The following is a description of a gene set: Mouse Gene Set: GOCC_ACETYLTRANSFERASE_COMPLEX studied in species Mus musculus A protein complex which is capable of acetyltransferase activity., and this is the list of marker genes: Morf4l1, Map3k7, Kat2a, Ogt, Kat2b, Taf6, Epc2, Epc1, Ep400, Tada1, Naa35, Dld, Actbl2, Hcfc1, Yeats2, Morf4l2 (NCBI Gene Id 71961), Naa11, Taf7, Brpf1, Naa30, Dlat, Pdha2 (pyruvate dehydrogenase E1 alpha 2), Naa38, Actg1, Sgf29, Ruvbl1, Kat6b, Taf12, Kansl1, Naa15, Crebbp (NCBI Gene Id 547230), Phf20, Naa20, Brpf3, Tada2a, Ing5, Sf3b3, Eny2, Brd8, Taf6l, Mbtd1, Kat14, Kat8, Actl6a, Naa50, Msl1 (NCBI Gene Id 76554), Actl6b, Ing3, Atxn7l3, Naa12, Ep300, Atf2, Msl2, Kat7, Tada3, Naa10, Dmap1, Pole3, Kat5, Yeats4, Taf2, Mrgbp, Brd1, Msl3l2, Ing4, Atxn7, Jade3, Supt3, Mcrs1, Brd8dc, Jade1, Taf5, Meaf6, Kat6a, Phf20l1, Naa16, Pdhx, Tada2b, Jade2, Msl3, Kansl2, Kansl3, Pole4, Mbip, Actb, Taf9, Zzz3, Pdhb, Vps72, Taf10, Taf4, Taf5l, Usp22, Supt20 (SPT20 SAGA complex component), Trrap, Dr1, Wdr5, Naa25, Taf9b (NCBI Gene Id 407786), Supt7l, Sf3b5, Ruvbl2, Kansl1l, Acte1